The following is a description of a gene set: Mouse Gene Set: GOBP_PROLINE_BIOSYNTHETIC_PROCESS The chemical reactions and pathways resulting in the formation of proline (pyrrolidine-2-carboxylic acid), a chiral, cyclic, nonessential alpha-amino acid found in peptide linkage in proteins. species: Mus musculus, and this is the list of marker genes: Noxred1, Oat, Pycr1, Pycr3, Pycr2, Aldh18a1